Given this list of marker genes MAPK1, PIK3CD, RAF1, PIK3R1, AKT1, MKNK2, TSC1, MAP2K1, EIF4EBP1 (eukaryotic translation initiation factor 4E binding protein 1), MAP3K5, MAP3K11, PBK, PIK3R3, PIK3R2, MAPK3, TSC2, PRKAA1, MAP2K2, MAP2K3, MKNK1, MAP2K6, PIK3CB, MTOR, EIF4E, PIK3CA, here is a description of the gene set: Human Gene Set: WP_4HYDROXYTAMOXIFEN_DEXAMETHASONE_AND_RETINOIC_ACIDS_REGULATION_OF_P27_EXPRESSION species: Homo sapiens 4-hydroxytamoxifen, dexamethasone, and retinoic acids regulation of p27 expression